The following is a description of a gene set: electronically inferred by orthology from the curated human pathway part of: Drug ADME This event has been computationally inferred from an event that has been demonstrated in another species.<p>The inference is based on the homology mapping from PANTHER. Briefly, reactions for which all involved PhysicalEntities (in input, output and catalyst) have a mapped orthologue/paralogue (for complexes at least 75% of components must have a mapping) are inferred to the other species. Reactome Pathway: Aspirin ADME studied in species Mus musculus, and this is the list of marker genes: Bsg, Ugt1a8, Ugt1a1, Ces2h, Ugt2b36, Ugt2a2, Alb, Ugt2a3, Abcc2, Ugt2b35, Ugt1a9, Bche, Ces1d, Acsm2, Acsm5, Acsm4, Glyatl3, Cyp3a25, Abcc3, Ugt1a7c, Cyp3a41a, Ugt2b37, Cyp3a44, Cyp2c65, Ugt1a5, Cyp3a57, Cyp3a16, Cyp3a11, Cyp2e1, Cyp2d22, Ugt1a6a, Cyp3a13, Ugt2a1, Ugt3a1, Ugt2b1, Ugt2b38, Cyp2c66, Cyp3a41b